Given this list of marker genes SARAF, CANX, DUSP14, UPF3A, OXR1, TOP2A, DIAPH3, RAPH1, POLE2, BEND6, KBTBD6, NCK1, EED, RSRC1, DHX15, WDR33, NUF2, HNRNPLL, MDM1, SMC4, PPP3CA, RCHY1, SCAI, KRT10, KTN1, PPM1A, COCH, PRKAR2B, NBEAL1, MPHOSPH9, ING1, SMARCA5, YTHDC2, MAPK6, AXL, CEP15, SRR, AOX1, NUDCD1, NUCB2, TTC32, SNTB2, CWC27, PRPS2, PAICS, ACAP2, EIF1B, HMGN5, AP5M1, ELK4, TXNL4A, CIP2A, SMIM3, ZWINT, MLLT10, CPSF6, MID1, NDC80, MZT1, MEA1, SEH1L (SEH1 like nucleoporin), TSHZ1, CEP20, OTUD6B-AS1, SPIN4 (NCBI Gene Id 139886), BLZF1, SPC24, VAMP7 (vesicle associated membrane protein 7), NUP54, SNRNP70, SAR1A, SMURF2, SLC25A24, STAM2, DTD2, TTK, MYBL1, HNRNPA1P37, HAUS6, IPP, NDUFA6, PIH1D1, ANP32E, SET, FANCI, SEC23B, MAP1LC3B, NOL7, TIMM17A, POLR1H, EIF4E2, PHAX, FBXO11, SENP7, CCNJ (NCBI Gene Id 54619), PDK3, POLA1, PSAT1, CCDC138, POLR3E, NAA15, ITGAE, ZNF330, RUFY3, EXOSC2, CDCA7L, GOLT1B, MIB1, TCF7L2, MCM8, RUNDC3B, RACGAP1, ATG3, YRDC, PHF20, SNRPA1, ALDH7A1, CDC42BPA, CYP2U1, POLD3, KIF20B, SMNDC1, YAP1, SEC14L1, PM20D2, PPP4R3B, XRCC4, C9orf40, NINJ2, NUDT21, IFT80, CKS1B, DKC1 (dyskerin pseudouridine synthase 1), ALG10B, DIMT1, TECPR2, STMN1, SLC7A5, MLF1, PER2, NIP7, MIR3939, GALM, IARS1, LRCH3, SRSF3, GTPBP4, C6orf52, RP2, TMX4, FSCN1, MRPL47, ATP9B, LUC7L2, UQCRC2, SMAD5, ENSG00000304354, PDIA6, ZNF273, HMGB1P4, RFXAP, LSM14A, BDP1, SLC25A43, GOLIM4, ANKRD44, PCNA, SLC7A1, CKAP2, ETV5, POMK, RNASEH2A, AP1G1, MTO1, SDC3, TRMT5, LRR1, ASNSD1, POLH, TMSB15B, FOXN2, PAWR, EWSR1, JADE1, LSM10, THAP5, FAM72C, PPM1B, CDCA8, TOMM6, CBX1, ARFIP1, RPA3, EVA1A, MAP3K13, DCUN1D1, PLK4, TUBB2A, PER3, QSER1, RBM17, CENPM, TK1, PDHA1, HBEGF, CTDSPL2, RBMS1, TYMS, RAPGEF2, TCEA1, BICD1, SPTSSA, RTKN2, MRE11, POLE4, KLHL15, TSPYL1, PHOSPHO2, MKKS, ZNF652, POU4F2, ZNF639, GMPS, SMCHD1, HNRNPM, ATP5IF1, TIPARP, BLTP3B, CTSC, CYB5A, ALYREF, IPMK, MARCHF1, ALG10, ATXN1L, PCNP, ALDH18A1, LSM5, GK5, TMEM97, PHF6, PPT1, EIF1AX, KLHL23, EXOSC8, TMEM237, PDS5B, MTF2, PTTG3P, TCF12, POGK, SNHG33, FOSL2, RIMS2, EIF4E, EBAG9, NOG, WDR43, CHTOP, SKA3, SLC35A5, SLC35D1, C4orf46, PABIR2, RPA1, ELOC, CHROMR, KLHL20, SUB1, BAG4, SNHG14, POC1B (POC1 centriolar protein B), ZNF670, RIOK2, STT3B, ZMYM5, SKP2, USP6, CNOT6L, SNX16, KAT6A (lysine acetyltransferase 6A), MAD2L1, HELLS, CRNDE, WSB2, MYSM1, IFRD1, ATP1B1, SUDS3, ZNF814, PRDM16-DT (PRDM16 divergent transcript), NDFIP2, MRPL35, RFC4, ABCB10, PLLP, MASTL, MED27, NUCKS1 (NCBI Gene Id 64710), CEP57, RAB33B, NCAPG, ZNF367, LYSMD3, NAPEPLD, NUB1, FLOT1, PHTF2, C5orf22, IPO9, FERMT2, BCAT1, TIPRL, VMA21, CREM, SKA2, NR2C1, PPP1R8, ECPAS, BMI1, TRA2B, DLGAP5, PLSCR1, DCTN4 (dynactin subunit 4), CDC6, ZIC2, KLHL42, ATL3, GAS5, ZNF765, RNF138, TNRC6B, PSMD12, FILIP1, ASPH, TCF19, CPNE8, KANSL1L, MCM4, COX7B, EEF1E1, OTUD6B (OTU deubiquitinase 6B), H2BC9, TMEM267, PHF19, SOCS3, NKTR, NUP107, STRN3, SUGT1, VRK2 (NCBI Gene Id 7444), PRPF40A, NPIPB13, ARID1A, PRC1, RFC5, RHOT1, RAD51AP1, FBXO8, CNIH1, MOSMO, CTNNB1 (NCBI Gene Id 1499), AK6, MYH10, CCAR1, SNX7, LIG3, TMED4, SUV39H2, RIF1, ECHDC1, RPE (ribulose-5-phosphate-3-epimerase), NEK2, PLPP3, CSGALNACT2, RBM12 (NCBI Gene Id 56682), SRFBP1, GNB4, LSM8, DESI2, PGGT1B, FBXL5, HNRNPC, SSR3, CSNK2B, FKBP5, PACRGL, TSEN15, KLHL8, CDC26, UBAP2, ZNF274, EP300-AS1, SPIN1, ATAD2 (NCBI Gene Id 84325), CCDC43, WAC-AS1, ORC2, C1orf122, PEX5L, CETN3, POMP (NCBI Gene Id 51371), CSAD, FAM204A, MT-ND6, POLR2B, PCNX4, WASH9P, PCMT1, SOWAHC, SP2-AS1, CFL2, YARS1, TMED7 (NCBI Gene Id 51014), MELK, NCAPH, BTG3, PSMC6, BRIP1, KIF2A, ZCCHC7, RABGAP1L, ZNF451, TRA2A, HNRNPR, SOCS6, SNRPC, RPAIN, TJP1 (NCBI Gene Id 7082), TAF13, RUFY2, CSE1L, DEK, MAN2A1, SLF1, BDNF, SGO2, CPLANE1, ZNF506, OSBPL11, AASS, MSH2, MYO5A, ASNS, UTP15, AP1S2, PTBP3, CUL3, UHRF1, SLC7A11, SFPQ, MCM6, SELENOK, CCPG1, SRP19, MORC3, RFK, ATF2, DTL, PBK, SLC3A2, NQO1, CISD2, EXOSC4, FH, SETD2, DNAJC3, TAF9B, TPT1-AS1, CDKL1, KIF18A, TIPIN, GLUD1 (glutamate dehydrogenase 1), TMEM50A, METTL2B, MRM2, CSRNP3, ODR4, STT3A, PRKD3, APCDD1L-DT, CCNA2, GINS3, USP38, STYK1, CDC42SE1, ING3, IQSEC3, COPS3, ZNF24, SPC25, KNSTRN, YTHDC1, H1-1, SEM1, TWSG1, PFKFB3, IQGAP3, NAE1, DNAJC24, STARD3NL, UBXN2A, PIGX, EMSY-DT, PPHLN1, CSPP1, RBM15, MBNL1, TMPO, DSG2-AS1, PANK2 (pantothenate kinase 2), MSH6, KIF15, DPYD, FIGNL1, WDR76, GINS1, GAS2L3, DNAJB6, ZNF559, LNPK, NDUFA11, RBL1, N4BP2, CMC2, NUP35, SBNO1, ERAP2, ERVK3-1, HNRNPD, ATP2C1, TMEM14C, RAP2A, LINC01355, ALCAM, FLVCR1, SIX1, RBM22, NSD3, PBDC1, IMMP1L, AEBP2, USP37, BNIP2, JUN, ATP5ME, RASSF8-AS1, DMAC2L, UBA6, PTTG1, TCP1, MRPL13, RFC2, ZC3H4, DBTP1, RYBP, CCNE2, DPY19L2P2, TPM1, PLEKHA3, CCDC14, FBXO5, ELAVL1, SERP1, MDM4, LCTL, HIGD1A, TUBGCP3, PWRN1, SGMS1, RBMXL1, U2SURP, MTBP, IER3IP1, ARHGEF12, TMTC3 (NCBI Gene Id 160418), CDC42SE2, CEPT1, FSTL1, YES1, LINC02637, MGC16275, RECQL, DCAF13, HTATSF1, CEP128, SYNCRIP (NCBI Gene Id 10492), NCAPG2, ERGIC2, CENPA, UHMK1, FANCD2, GINS2, CTPS1, KIAA1586, IWS1, BCL10, HDGFL3, MTPAP, TFDP1, PTEN, SMIM8, PITHD1, WDHD1, ZNF721, PRKRA, ADK, RRM1, C1GALT1, NUP50 (nucleoporin 50), KPNA3, INSYN2B, NUDT15, UBE2G1 (NCBI Gene Id 7326), PRRC2C, DENR, CENPN, MBLAC2, MRPS9, CBFB, BARD1, SERTAD2, KIF23, HMGN4, WTAP, SLC30A5, CNOT8, TIMM21, PALS2, NOSIP, E2F8, UBXN7, DLEU2, QKI, PRKAR2A, UCHL3, CENPE, ASPM, MIS18A, PSIP1, THAP9-AS1, LAMP2, BRD2, MNAT1, GFM1, PCDHGA8, ZCCHC10, TOMM5, CEP76, MBD2, GTF2H2, SMIM15, TM2D3, ESCO2, CDKN2C, FAM13B (NCBI Gene Id 51306), DR1, RAMAC, MPHOSPH6, MALSU1, ZWILCH, CDK6, ZNF23, BUB1, G3BP2, ALDH6A1, DEPDC1B, MLF1-DT, PTK2, MNS1, UAP1, TCP10L, OIP5, TMEM200B, WAC, TOR1AIP2, CENPF, ELL2, GORASP2, NUP160, PIK3CB, SMC3, KLHDC10, ATR, ZNF22, TAX1BP1, LSP1P5, HOOK3, MTHFD2 (NCBI Gene Id 10797), NUP42, TPRKB, MRPS18C, NOL11, RRM2, RIT1, ZNF234, EZH2, DBF4, CPSF3, SUCO, BRIX1, RAPGEF6, HSPA13, SMC2, TPI1, CCND3, IFT56, TMEFF1, ZNF587, HACD3, NOP58, VPS54, UQCC2, ACTL6A, SLC6A6, PXK, GPN3, G2E3, MTERF3, SFXN1, MICB, NAA50 (NCBI Gene Id 80218), RSPH10B, SLK (STE20 like kinase), HERPUD2, PLEKHB2, YTHDF2, INCENP, NUSAP1 (NCBI Gene Id 82534), NDUFS5, ACTN1, SLC25A32, BIRC5, FAM98A, SPAG5, POLR2D, ZNF718, CMSS1, EIF5, PARVA, RALBP1, ARHGAP11A, SHCBP1 (SHC binding and spindle associated 1), ING2, MELTF-AS1, RIOX2, ANKRD28, CSNK1A1, GTF3C3, BMPR2, H2AZ2, C2orf69, PPP4R2, TDG, RAB12, SEPTIN10, CISD1, NUDT19, GLO1, ID1, CBX5, AGBL3 (AGBL carboxypeptidase 3), AZI2 (5-azacytidine induced 2), TAS2R15P, USP1, CENPW, ID3, MRPS22, SSR1, MCTS1, LSM2, DOP1A, EBNA1BP2, MYCBP, PET117, CNOT9, UBE2V2, RAB18, C8orf76, CELF1, BROX, IRF2BPL, CEP350, SACS, FBXW7, NDUFB7, DTYMK (NCBI Gene Id 9102), FLCN, RUVBL2, MIS18BP1, CEP70, COPS2, MGP, C1orf174, TMCO6, PTMA, MAP3K2, FRMD6, KCNAB1, CDC20, FUBP1, PRKDC, EME1 (NCBI Gene Id 146956), ELOA, ENY2, THOC7, SASS6, BUB3, MAP3K20 (mitogen-activated protein kinase kinase kinase 20), PPP1CB, TAF11, PTBP2, FCF1 (NCBI Gene Id 51077), CAPS2, PAFAH1B2, MED19, MAGOHB, SACM1L, MED4, BMPR1A, FGD5-AS1, FMR1, TAF1D, GTF2A2, ZNF567, SYNJ2BP, COPS4, ZC3HAV1L, PRPF31, TMEM209, GPSM2, SEC22C, MYO1B (NCBI Gene Id 92451), MIGA1, CDK1, NT5E, TMX1, ORC4, NUTF2, CASP2, KIF2C, RMI1, ODC1, N4BP2L2, ZNF738, KIF11, C17orf75, COPS8, IVNS1ABP, UNG, SGTB, ABI2, NEK4 (NCBI Gene Id 8380), CARNMT1, HMGB1, REST, TNPO1, GMNN, CAST, SNRPF, GTF2H3, OPA1, MTRFR, SERTAD4, SEC22B, OBI1, CTTN, SLC36A4, GLS, RPA2, GPX8 (glutathione peroxidase 8 (putative)), ADI1, PIGW, RASAL2, TFAM, DCLRE1C (DNA cross-link repair 1C), here is a description of the gene set: species: Homo sapiens from publication Johnstone CN, Mongroo PS, Rich AS, Schupp M, Bowser MJ, Delemos AS, Tobias JW, Liu Y, Hannigan GE, Rustgi AK (PMID 17998334) Parvin-beta is a focal adhesion protein downregulated in human breast cancer cells. Loss of Parvin-beta contributes to increased integrin-linked kinase activity, cell-matrix adhesion, and invasion through the extracellular matrix in vitro. The effect of ectopic Parvin-beta expression on the transcriptional profile of MDA-MB-231 breast cancer cells, which normally do not express Parvin-beta, was evaluated. Particular emphasis was placed upon propagating MDA-MB-231 breast cancer cells in three-dimensional culture matrices. Interestingly, Parvin-beta reexpression in MDA-MB-231 cells increased the mRNA expression, serine 82 phosphorylation (mediated by CDK9), and activity of the nuclear hormone receptor peroxisome proliferator-activated receptor gamma (PPARgamma), and there was a concomitant increase in lipogenic gene expression as a downstream effector of PPARgamma. Importantly, Parvin-beta suppressed breast cancer growth in vivo, with associated decreased proliferation. These data suggest that Parvin-beta might influence breast cancer progression. Human Gene Set: JOHNSTONE_PARVB_TARGETS_3_DN Genes down-regulated upon overexpression of PARVB in MDA-MB-231 cells (breast cancer) cultured in 3D Matrigel only.